The following is a description of a gene set: Human Gene Set: GOBP_SMOOTH_MUSCLE_CELL_PROLIFERATION The multiplication or reproduction of smooth muscle cells, resulting in the expansion of a cell population. species: Homo sapiens, and this is the list of marker genes: RGCC, ACE2, MIR208A, PAK1, PPARGC1A, NAA35, EDN1, MIR4632, MAP3K7, IL13, MIR145, MIR223, NOTCH3, AIF1, PRKG1, MIR135B, TGFB1, MIR34A, XRCC6 (NCBI Gene Id 94359), NF1, PDGFRB, TNF, PTGIR, GSTP1, MIR222, GJA1, PRKCA, MIR27A, IRAK4, THBS1, DDR2, PDGFD, APLN, MIR182, MEF2D, MIR362, HTR1B, MIR21, ANG, XBP1, BMP2, CCL5, TCF7L2, MIR448, KLF4, MIR140, POLDIP2, CALCRL, AKT1, ITGB3, IL12A, MIR214, BMP4, PTEN, PDE1A, LDLRAP1, PPARD, CYBA, FGF9, HPGD, NPR1, S1PR1, ELN, MIR143, SKP2, IL12B, XRCC5, MIR638, MIR499A, DNMT1, TPM1, NOX1, MIR665, P2RY6, ELANE, TERT, IL10, FOXP1, CDH13, FGF2, MIR1298, CX3CL1, PRKDC, MIR185, DBH, PDGFB, MIR146A, ERN1 (endoplasmic reticulum to nucleus signaling 1), MDM2, STAT1, GPER1 (G protein-coupled estrogen receptor 1), MIR301A, MEF2C, GNAI2, MIR137, MIR96, SOD2, ITGA2, MNAT1, JAK2, CTNNBIP1, MIR27B, EFEMP2, TGFB3, MIR20A, BMPR2, MIR503, TLR4, HDAC1, MIR339, MYD88, PDCD4, TAFA5, ID2, MIR221, GNA12, IGF1, APOD, FOXJ2, IGFBP5, CDKN1A, MIR17, NDRG4, APOE, FGFR2, CTNNB1, IRAK1, NPY5R, MIR1-1, MIR26A1, MMP2, MYB, MIR133A1, SF1, PPARG, RGS5, JUN, MMP9, HBEGF, DDIT3, HMOX1, MFN2, CCN4, MIR15A, RBPMS2 (RNA binding protein, mRNA processing factor 2), IFNG, IL18, ADAMTS1, OGN, NPPC, IGFBP3, SERPINF2 (NCBI Gene Id 5345), NOS3, IL6R, MIR424, IL6, MYOCD, SMPD3, TNFAIP3, MIR130A, PHB1, CCN3, PIK3CA, TACR1, TRIB1, MAP3K5, PIK3R1, ADIPOQ, CNN1, HES5, NR4A3, NDRG2, BMPR1A, RBM10, CDKN1B, EREG